The following is a description of a gene set: studied in species Homo sapiens Human Gene Set: HP_ABSENT_NIPPLE Congenital failure to develop, and absence of, the nipple. Absent nipple, and this is the list of marker genes: RSPO2, EDARADD, TWIST2, KMT2D, PTPRF, FIG4, TP63, EDA, CDH11, SLC25A24, KDM6A